The following is a description of a gene set: Enhanced secondary Ab responses are a vital component of adaptive immunity, yet little is understood about the intrinsic and extrinsic regulators of naive and memory B cells that results in differences in their responses to Ag. Microarray analysis, together with surface and intracellular phenotyping, revealed that memory B cells have increased expression of members of the TNF receptor, SLAM, B7 and Bcl2 families, as well as the TLR-related molecule CD180 (RP105). Accordingly, memory B cells exhibited enhanced survival, proliferation and Ig secretion, as well as entered division more rapidly than naïve B cells in response to both T-dependent and T-independent stimuli. Furthermore, both IgM and isotype switched memory B cells, but not naïve B cells, co-stimulated CD4+ T cells in vitro through a mechanism dependent on their constitutive expression of CD80 and CD86. This study demonstrates that upregulation of genes involved in activation, co-stimulation and survival provides memory B cells with a unique ability to produce enhanced immune responses and contributes to the maintenance of the memory B cell pool. Human Gene Set: GSE13411_NAIVE_VS_SWITCHED_MEMORY_BCELL_UP from publication Good KL, Avery DT, Tangye SG (PMID 19124732) species: Homo sapiens Genes up-regulated in comparison of naive B cells versus Ig isotype switched memory B cells., and this is the list of marker genes: AGFG2, CHRNA9, BOK, PCYT1B, CBS, MVD, GLB1L2, KRT6B, CHIA, CLDN6, MLNR, ADH1C, ART1, GCG, ADORA1, EIF5A2, MS4A2, GPR161, CNTLN, MYB, EYA1, PALLD, MAGEL2, DGKI, BCHE, CADM4 (cell adhesion molecule 4), CAMK2B, TAS2R9, SLC6A6, CACNG1, SCG5, TUBA3D, CABP5, SLC26A2, FGF18, PPP1R37, FLG, GIT1, KRT19P2, LMO3, NID1, FAM124B, MYCT1, OTUD7B, LDLR, TLN2, KLRG1, NDRG4, SLC22A17, CYP2F1, MFAP3L, HIF3A, SEMA3C, FZR1, VEGFC, INPP5J, PARVA, NPAP1, SLCO1B3, NFATC4, IL6, HIPK3, NXPH4, WT1, TUBA4B, MSMB, AGRP, SYP, DPF3, TRIM10 (tripartite motif containing 10), RPL6, QPRT, GCNT3, MZB1, OSMR, DCN, AKAP12, SNTG2, SULT4A1, ORM1, ENTREP2, FRZB, ANGPTL7, MYL1, PPARGC1A, HCRT, HES2, PCDHA2, INTS9, ANKRD26, COL5A3, DMPK, PPP4R4, SLN (NCBI Gene Id 84783), PDLIM4, PLK4, ACAT2, RGS11, BPNT1, TRGV5, MTMR2, OR7C1, DLG3, MATK (NCBI Gene Id 4145), CYP3A7, OLFM1, CDH3, EFCC1, NYX, ATP7B, PAK6, NPTX1, EDNRA, B2M, OR2S2, CDADC1, HR, GNL1, TECTA, SCNN1G, NPY4R, PRSS50, HPD, CALCA, SELE, HPCAL4, TMEM262, NECTIN3, RGN (regucalcin), RIMS1, CLC, PRAMEF12, RASGRF1, SEZ6L, PLEKHH3, ENSG00000284948, HSD17B1, MAGEB3, DCAF11, FJX1, GPR107, HEPH (NCBI Gene Id 9977), GSDMB, IQCH, ARC, NPAS3, RTN1, RNLS, OVOL1, ADCY10, DIAPH1, TBC1D10B, PDE12, SND1-IT1, NXF3, SLC5A4, WFDC2, MYH10, DRD5 (dopamine receptor D5), NBL1, PDX1, PRRC1, GRTP1, FAM169A, AQP8, HSPBP1, MORC1, ZNF446, GLYAT, TEAD3, LHB, CCDC57 (NCBI Gene Id 284001), MTHFSD, PRR36, FNTB, WNT8B, JRK, INSL5, AMOT, MMP20, AFP, DSCC1, NAT8B, SLC39A2, OR10C1, BMAL2, SLCO5A1, LGALSL, TRPC2, ANKRD53, PDZRN4, SNAI2, CD72, SYNE3, EDN2, GUSBP11, ANKRD1, MTMR7